The following is a description of a gene set: Mouse Gene Set: MIR_698_3P studied in species Mus musculus Genes predicted to be targets of miRBase v22 microRNA mmu_miR_698_3p in miRDB v6.0 with MirTarget v4 prediction scores > 80 (high confidence targets). from publication Chen Y, Wang X (PMID 31504780), and this is the list of marker genes: Kdm1a, Rab33a, Sema7a (NCBI Gene Id 78407), Ric1, Uncx, Mea1, Kcns2, Nav2, Usp18, Mrpl46, Cpsf4l, Plcb1, Ccng1 (NCBI Gene Id 12450)